Given this list of marker genes TKFC, DDX60, RIOK3, USP17L2, ANKRD17, C1QBP, DHX58, here is a description of the gene set: Any process that modulates the frequency, rate or extent of the series of molecular signals generated as a consequence of the cytoplasmic pattern recognition receptor (PRR) MDA-5 (also known as IFIH1) binding to viral RNA. Human Gene Set: GOBP_REGULATION_OF_MDA_5_SIGNALING_PATHWAY species: Homo sapiens